Given this list of marker genes GLYCTK, SORD, SLC2A2, TPI1 (triosephosphate isomerase 1), KHK, PGM1, FBP1, ALDOB, PFKL, GPI, ALDH1A1, G6PC1, SLC5A1, HK1, here is a description of the gene set: Human Gene Set: WP_DISORDERS_OF_FRUCTOSE_METABOLISM studied in species Homo sapiens Disorders of fructose metabolism